The following is a description of a gene set: Human Gene Set: GOCC_SORTING_ENDOSOME studied in species Homo sapiens A multivesicular body surrounded by and connected with multiple tubular compartments with associated vesicles., and this is the list of marker genes: CLTCL1, LDLR, KDR, ARHGAP1, PTPN1, NRP1